Given this list of marker genes SLFN14, ATF4, EIF2S1, ADAM9 (NCBI Gene Id 8754), BACE1, LRRK2, PRKN (NCBI Gene Id 8004), D2HGDH, EIF2AK3, APP, SOD2, TSPO, ATP13A2, TFRC, HSP90B1, here is a description of the gene set: studied in species Homo sapiens Any process that results in a change in state or activity of a cell or an organism (in terms of movement, secretion, enzyme production, gene expression, etc.) as a result of a manganese ion stimulus. Human Gene Set: GOBP_RESPONSE_TO_MANGANESE_ION